Given this list of marker genes SORL1, ESRP2, SETD1A, PLEKHM1, CXCR2, PPRC1, ANKRD60, TAS1R3, ITPA (inosine triphosphatase), TNFAIP8L2, GRK6, QSOX2, ABLIM3, C7orf25, TMIGD1, NCF2, LFNG, TCAF2, MARCHF8, B4GALT6, GUCY1A2, AOAH, WSB2, PTGIS, NSG1, RPS6KA2, CD200R1L, TCF7, CFAP100 (cilia and flagella associated protein 100), EIF3E, EIF2AK1, IFRD2, TTC38, HECW1, DSP, PWWP3B, TMEM174, DIS3L, ACTR5, FIZ1, RPAP3 (NCBI Gene Id 79657), MON2, DIPK1A, FFAR4, CACNA1F, HNF1A, RRP8, KLHL38, GEMIN4 (gem nuclear organelle associated protein 4), THOC5, LRIG3, ORM1, CYRIB, CPB2, KCTD1, OGN, TTLL5, ARMC1, LAMTOR3, MIR217, AMIGO3, KCNK18, CCL26, SPINK8, GALC, NTNG1, PTPRU (protein tyrosine phosphatase receptor type U), NRK, ALPK2, MLST8, VIPR1, DCTN1, UCMA, CHMP7, CALHM6, EIF3B, MIR450B, TMCO5A, CYLC1, PSMD7, PDCD10, ZBTB44, LRRC7 (leucine rich repeat containing 7), TXNL4B, SLC66A1, SHARPIN, CLDN12, PRPS1L1, DNAJB9, CYP4X1, AXIN1, RFTN1, TRIM40, PRAME, SLC25A18, MAPKAP1, IL6R, ATP6V1D, UCN2, CYP2G1P, SPATA2, HSPBAP1, ATXN7L3, EARS2, MAP3K3, HOXC13, POLR2M, GLRB, IL23R, UBA2, CACNB3, GJA5, OAS2, CHODL, JMJD4 (jumonji domain containing 4), ZBTB9, FEM1A, MINPP1, CRP, HIGD1A, FRAT1, FAM168B, NFATC3, JOSD2, SPATA2L, MRO, STAT3, PIGR, PNMA5, TRMT10B, ADPGK, SERPINB8, ITPKC, TMEM81, CD2, here is a description of the gene set: Human Gene Set: GSE9946_MATURE_STIMULATORY_VS_PROSTAGLANDINE2_TREATED_MATURE_DC_UP Myeloid dendritic cells (DC) and macrophages play an important role in pathogen sensing and antimicrobial defense. Recently we demonstrated that infection of human DC with intracellular bacterium Listeria monocytogenes (L.monocytogenes) leads to the induction of the immunoinhibitory enzyme indoleamine 2,3-dioxygenase (Popov et al., J Clin Invest, 2006), while in the previous studies L.monocytogenes infection was associated with a rather stimulatory DC phenotype. To clarify this discrepancy we performed comparative microarray analysis of immature mo-DC (immDC), mature stimulatory mo-DC (matDC) and mature inhibitory DC either stimulated with prostaglandin E2 (PGE2-DC) or infected with L.monocytogenes (infDC). Studying infection of human myeloid DC with Listeria monocytogenes, we found out, that infected DC are modified by the pathogen to express multiple inhibitory molecules, including indoleamine 2,3-dioxygenase (IDO), cyclooxygenase-2, interleukin 10 and CD25, which acts on DC as IL-2 scavenger. All these inhibitory molecules, expressed on regulatory DC (DCreg), are strictly TNF-dependent and are in concert suppressing T-cell responses. Moreover, only DCreg can efficiently control the number of intracellular listeria, mostly by IDO-mediated mechanisms and by other factors, remaining to be identified. Analyzing publicly acessible data of transcriptional changes in DC and macrophages, infected by various pathogens and parasites (GEO, GSE360), we noticed that infection of these cells with Mycobacterium tuberculosis causes transcriptional response, comparable with the one caused by listeria in human DC. In fact, granuloma in tuberculosis and listeriosis in vivo are enriched for myeloid DC and macrophages characterized by regulatory phenotype. In summary, regulatory myeloid DC and macrophages may play a dual role during life-threatening granulomatous infections, such as tuberculosis: on one hand, regulatory myeloid cells promote pathogen containment by efficiently killing intracellular bacteria, on the other hand these cells inhibit granuloma-associated T cells and thereby might be involved in the retention of TNF-controlled granuloma integrity protecting the host from granuloma break-down and pathogen dissemination. studied in species Homo sapiens Genes up-regulated in mature dendritic cells: stimulatory versus inhibitory treated by prostaglandin E2. from publication Popov A, Driesen J, Abdullah Z, Wickenhauser C, Beyer M, Debey-Pascher S, Saric T, Kummer S, Takikawa O, Domann E, Chakraborty T, Krönke M, Utermöhlen O, Schultze JL (PMID 18802101)